The following is a description of a gene set: Cytokines mediate cell-cell communication in the immune system and represent important therapeutic targets. A myriad of studies have highlighted their central role in immune function, yet we lack a global view of the cellular responses of each immune cell type to each cytokine. To address this gap, the authors created the Immune Dictionary, a compendium of single-cell transcriptomic profiles of more than 17 immune cell types in response to each of 86 cytokines (>1,400 cytokine-cell type combinations) in mouse lymph nodes in vivo. A cytokine-centric view of the dictionary revealed that most cytokines induce highly cell-type-specific responses. For example, the inflammatory cytokine interleukin-1β induces distinct gene programmes in almost every cell type. A cell-type-centric view of the dictionary identified more than 66 cytokine-driven cellular polarization states across immune cell types, including previously uncharacterized states such as an interleukin-18-induced polyfunctional natural killer cell state. Genes positively differentially expressed in cell type: B cell upon treatment with cytokine: G-CSF in mouse lymph nodes in vivo. Mouse Gene Set: CUI_B_CELL_G_CSF_RESPONSE_UP from publication Cui A, Huang T, Li S, Ma A, Pérez JL, Sander C, Keskin DB, Wu CJ, Fraenkel E, Hacohen N (PMID 38057668) species: Mus musculus, and this is the list of marker genes: Slc50a1, Ddx50, Cdc25b, Idh3g, H4c4